Given this list of marker genes TMEM192, IL10, NDUFAF4, APOOL, CCL4, MARCHF5, PML, IL18, FCGR1A, DNAJC11, BBX, GARS1, CST7, FGR (FGR proto-oncogene, Src family tyrosine kinase), EMB, LGALS3BP, NOC3L, C11orf24, FAP, SCHIP1, AKAP12, MED9, RALGDS, RBM43, NAA20, PGS1, PMEPA1, UBC, CD40, ATP6V1G1, SLC39A14, HIF1A, PLSCR1 (phospholipid scramblase 1), VDR, IPO4, AEBP2, FOS, TLR6, ALDH1A2, CCDC86, PNO1, HP, TOR1AIP1, IFITM3, UBA7 (NCBI Gene Id 7875), MAFF, RRP1B, ATP11A, C11orf96, DDX24, TPST1, SH3BP2, CLIC4 (chloride intracellular channel 4), HCAR2, STK39, IRF8, HSPA4, TIMM8A, TXN, MAP3K6, PSMB8, MEFV, THBS1, NDUFAF1, LYVE1, PSAT1, PSMB2, PTGES, ZC3H12A, RSAD2, OGFRL1, LOX, RHOJ, KARS1, KCNE4, TOMM70, F2RL3, FARSA, KTN1, MYC, TUBB6, CRYBB3, IRF7, HDC, ITGA5, FLNB, PAX4, ETF1, CTPS1, TAP1, RCN1, IL1A, TLR2, ADPGK, NET1, SPRED1, TMEM184B, CCL7, NASP, CDKN2B, DDIT3, CXCL6, DDHD1, PSMB10 (proteasome 20S subunit beta 10), TIFA, SUPV3L1, STAT3, RBL1, PLXNA2, IL15RA, MOV10 (Mov10 RNA helicase), LIPG, MTHFD2, IL6, GRAMD2B, TIMP1, IFIT3, SLFN12, NFIL3, CD70 (CD70 molecule), ASB13, TSPAN3, SOCS3, JUNB, HK1, COL4A2, SAMSN1, VPS54, CLEC4D, IRF9, CD300LF, HMGN3, ACSL5, CASP4, FPR1, DNAJA2 (DnaJ heat shock protein family (Hsp40) member A2), SOWAHC, FNBP4, GNG12, DDX60, CDKN1A, STXBP1, PRKX, TBK1, FANCA, JAK3, SRM, PSMB9, PRPF31 (pre-mRNA processing factor 31), HEATR1, FCGR3A, OGFR, STXBP3, SOCS2, UBE2F, ATM, EIF6, SAP30, SERPINB9, SELL, CFB, MRPS22, MT1E, DUSP16, CACNB3, UBE2L3, SUSD6, CCND2, AOAH, FPR2, RNF114 (NCBI Gene Id 55905), TLR7, BACH1, ILRUN (NCBI Gene Id 79138), ADAMTS4, LUC7L, TTC39B, TIPARP, BRI3, SSU72, HELZ2, UBE2L6, HSPD1, BST1, AKT3, ENC1, SH3GL3, PKIB, PROCR, RAE1, CARS1, SNRPD1, PARP14, ZNRF1 (NCBI Gene Id 84937), MYD88 (MYD88 innate immune signal transduction adaptor), BYSL, KEAP1, JDP2, RARS1, RIPK2, here is a description of the gene set: Interleukin-21 (IL-21) is a pleiotropic cytokine that induces expression of transcription factor BLIMP1 (encoded by Prdm1), which regulates plasma cell differentiation and T cell homeostasis. We identified an IL-21 response element downstream of Prdm1 that binds the transcription factors STAT3 and IRF4, which are required for optimal Prdm1 expression. Genome-wide ChIP-Seq mapping of STAT3- and IRF4-binding sites showed that most regions with IL-21-induced STAT3 binding also bound IRF4 in vivo, and furthermore, revealed that the noncanonical TTCnnnTAA GAS motif critical in Prdm1 was broadly used for STAT3 binding. Comparing genome-wide expression array data to binding sites revealed that most IL-21-regulated genes were associated with combined STAT3-IRF4 sites rather than pure STAT3 sites. Correspondingly, ChIP-Seq analysis of Irf4_/_ T cells showed greatly diminished STAT3 binding after IL-21 treatment, and Irf4_/_ mice showed impaired IL- 21-induced Tfh cell differentiation in vivo. These results reveal broad cooperative gene regulation by STAT3 and IRF4. Human Gene Set: GSE19198_1H_VS_6H_IL21_TREATED_TCELL_DN studied in species Homo sapiens Genes down-regulated in T cells treated with IL21: 1h versus 6h. from publication Kwon H, Thierry-Mieg D, Thierry-Mieg J, Kim HP, Oh J, Tunyaplin C, Carotta S, Donovan CE, Goldman ML, Tailor P, Ozato K, Levy DE, Nutt SL, Calame K, Leonard WJ (PMID 20064451)